Given this list of marker genes SLC35A3, YRDC, FGF9, PDPN, CSGALNACT1, TBX2, MYH3, TNNI2, SALL4, TGFBR1, DLL3, TBR1, RIPPLY2, COL12A1 (collagen type XII alpha 1 chain), WNT5A, IPO8, NALCN, MAPK1, NXN, TRPS1, FBXO28, CAPN3, GON7, KDM5C, OCRL, GDAP1, DOK7, FAT4, TCTN3, LAGE3, FERMT1, PORCN, LMBR1, RAB23, FZD2, COG5, BCR, SCN4A, NR4A2, NAA10, COL6A1, NOG, RAPSN (NCBI Gene Id 85713), FGD1, COL6A2, TWIST2, SMG9, TUBB3 (NCBI Gene Id 94749), TPM2, ERI1, CANT1, COL6A3, PEX6, CDC45, EZH2, SLC18A3, COL11A1, SHH (NCBI Gene Id 6469), TNNT3, CCN6, SLC26A2, PEX1, PTPN22, SKI, MED12, MYOD1, NUP88, IGHMBP2, MMP2, MAFB, ANTXR2, MUSK, MED25, GJA1, TGFB2, PSMB8, SMAD2, IL10, SPEN, L1CAM, POLR3GL, TUBA1A, GNPTAB, KRT14, HINT1, GDF5, GPC4, KIF21A, ARID1B, SMARCAD1, CRKL, HSPG2, ERCC2, NLRP3, GABRD, ERCC6, SH3PXD2B, CD244, COL1A1, CLCF1, CUL4B, LFNG, MYBPC1, MYL11, DVL3, MEGF8, DVL1, RAB33B, MBTPS2, RAB3GAP1, PRKCZ, CIITA, GPKOW, ARPC4, PIEZO2, ORC4, MATN3, PRDM16 (NCBI Gene Id 647868), TMEM70, SCARF2, TGFB3, POLR3A, SLC22A4, RPL10, NOD2, COL11A2, CCDC22, KAT6B, SUZ12, TGFBR2, CDT1, TGDS, LMNA, HOXD13, ALX3, CHST3 (carbohydrate sulfotransferase 3), MMP23B, TBC1D2B, TAF4, ACTG2, FBXO11, TDO2, ORC1, EMG1, MAGEL2, SMAD3, ZDHHC9, CASZ1, FBN1, SMC1A, ASPN, IDS, SLC29A3, NUP133, ZNF407, NSD1, LAMB3, TRAPPC2, ADAT3, NEDD4L, KAT6A, OSGEP, TRPV4 (NCBI Gene Id 8098), LIFR, PRG4, GPC3, EFNB1, PCGF2, ERCC5, MEGF10 (NCBI Gene Id 84466), ADAMTS3, SMARCA2, KCNK9, GMNN, WDR73, RERE, ADAMTSL2, CFTR, ZMPSTE24, CHRNG, SMARCA4, SMOC1, CCBE1, HES7, UBE4B, NFKBIL1, KCNAB2, ADAMTS15, H4C9, TOR1AIP1, COL2A1, MAP3K7, KDM5B, PIGL, RTTN, DHODH (dihydroorotate dehydrogenase (quinone)), APC2, FGFR1, FKTN, ALX1, FLNA, PLOD3, UPF3B, FGFR3, SLC35A2, ERCC1, IKBKG, ASXL3, SLC39A13, WFS1, WDR4, LUZP1, TLK2, XYLT1, TP53RK, MORC2, PAX3, CDC6, GNPNAT1, FBN2, TPRKB, MKS1, MESP2, TBX3, IDUA, NUP107, ORC6 (origin recognition complex subunit 6), BCOR, ROR2, CRLF1, here is a description of the gene set: species: Homo sapiens Human Gene Set: HP_ABNORMAL_PHALANGEAL_JOINT_MORPHOLOGY_OF_THE_HAND Abnormal phalangeal joint morphology of the hand